The following is a description of a gene set: The NOTCH4 gene locus was discovered as a frequent site of insertion for the proviral genome of the mouse mammary tumor virus (MMTV). MMTV-insertion results in aberrant expression of the mouse mammary tumor gene int-3, which was subsequently discovered to represent the intracellular domain of Notch4.<br><br>NOTCH4 is prevalently expressed in endothelial cells. DLL4 and JAG1 act as ligands for NOTCH4 in human endothelial cells, but DLL4- and JAG1-mediated activation of NOTCH4 have not been confirmed in all cell types tested. The gamma secretase complex cleaves activated NOTCH4 receptor to release the intracellular domain fragment (NICD4). NICD4 traffics to the nucleus where it acts as a transcription factor and stimulates expression of NOTCH target genes HES1, HES5, HEY1 and HEY2, as well as VEGFR3 and ACTA2. NOTCH4 signaling can be downregulated by AKT1 phosphorylation-induced cytoplasmic retention as well as proteasome-dependent degradation upon FBXW7-mediated ubiquitination.<br><br>NOTCH4 was reported to inhibit NOTCH1 signaling in-cis, by binding to NOTCH1 and interfering with the S1 cleavage of NOTCH1, thus preventing production of functional NOTCH1 heterodimers at the cell surface.<br><br>NOTCH4 is involved in development of the vascular system. Overexpression of constitutively active Notch4 in mouse embryonic vasculature results in abnormal vessel structure and patterning. NOTCH4 may act to inhibit apoptosis of endothelial cells.<br><br>Expression of int-3 interferes with normal mammary gland development in mice and promotes tumorigenesis. The phenotype of mice expressing int-3 in mammary glands is dependent on the presence of Rbpj. JAG1 and NOTCH4 are upregulated in human ER+ breast cancers resistant to anti-estrogen therapy, which correlates with elevated expression of NOTCH target genes HES1, HEY1 and HEY2, and is associated with increased population of breast cancer stem cells and distant metastases. Development of int-3-induced mammary tumours in mice depends on Kit and Pdgfra signaling and on int-3-induced activaton of NFKB signaling. In head and neck squamous cell carcinoma (HNSCC), high NOTCH4 expression correlates with elevated HEY1 levels, increased cell proliferation and survival, epithelial-to-mesenchymal transition (EMT) phenotype and cisplatin resistance. In melanoma, however, exogenous NOTCH4 expression correlates with mesenchymal-to-epithelial-like transition and reduced invasiveness (Bonyadi Rad et al. 2016). NOTCH4 is frequently overexpressed in gastric cancer. Increased NOTCH4 levels correlate with activation of WNT signaling and gastric cancer progression.<br><br>NOTCH4 is expressed in adipocytes and may promote adipocyte differentiation.<br><br>During Dengue virus infection, DLL1, DLL4, NOTCH4 and HES1 are upregulated in interferon-beta (INFB) dependent manner. NOTCH4 signaling may be affected by Epstein-Barr virus (EBV) infection, as the EBV protein BARF0 binds to NOTCH4. species: Homo sapiens Reactome Pathway: Signaling by NOTCH4 part of: Signaling by NOTCH, and this is the list of marker genes: UBC, HEY1, PSMC3, PSMC2, RBPJ, TACC3, HEY2, UBB, PSMB3, HES5, PSMB6, RBX1, YWHAZ, SEM1, PSMD12, PSMA2, PSMD14, PSMA5, PSMD11, FBXW7, MAML2, AKT1, PSMA4, NOTCH4, PSMA6, DLL4, SKP1 (S-phase kinase associated protein 1), PSMC6, PSMD8, NOTCH1, MAMLD1, RPS27A, NCSTN, JAG1, PSMB1, MAML3, PSMD7, EP300, CUL1, KAT2A, PSEN2, PSMB5 (NCBI Gene Id 5693), ADAM10, PSMA7, PSMB2, PSMC4, PSMB7, PSMD3, APH1B, PSMD6, SMAD3, HES1, CREBBP, PSMD2, APH1A, PSMD1, PSMD13, PSMC1, UBA52, ADRM1 (ADRM1 26S proteasome ubiquitin receptor), PSENEN, PSMC5, KAT2B, MAML1, ACTA2, PSMA3, PSMA1, NOTCH2, PSEN1, FLT4, SNW1, PSMB4